The following is a description of a gene set: species: Homo sapiens Human Gene Set: GSE29618_BCELL_VS_MDC_DAY7_FLU_VACCINE_DN Genes down-regulated in comparison of B cells from influenza vaccinee at day 7 post-vaccination versus myeloid dendritic cells (mDC) at day 7 post-vaccination. Systems vaccinology has emerged as an interdisciplinary field that combines systems wide measurements and network and predictive modeling applied to vaccinology. Here we used the systems vaccinology approach to study the molecular mechanisms underlying th from publication Nakaya HI, Wrammert J, Lee EK, Racioppi L, Marie-Kunze S, Haining WN, Means AR, Kasturi SP, Khan N, Li GM, McCausland M, Kanchan V, Kokko KE, Li S, Elbein R, Mehta AK, Aderem A, Subbarao K, Ahmed R, Pulendran B (PMID 21743478), and this is the list of marker genes: HEXB, ROGDI (rogdi atypical leucine zipper), AHNAK, LGALS2, CYFIP1, RIN3, NREP, APMAP, MYCL (MYCL proto-oncogene, bHLH transcription factor), COTL1, PTPRE, NDFIP1, ALDOA, IL13RA1, PEA15, CASP1, CLIC2, ADAM8, ACTB, RTN4, TUBA1C, RAB7A, RAB31, CKLF, RGCC, FZD1, CLEC7A, CSF2RA, CD1B, PTMS (NCBI Gene Id 5763), SAMHD1, TPI1, LDLRAD4, GRN, LGALS9, ALDH2, CD1D, CLEC4A, LMO2, RAB32, SHTN1, OTULINL, C1orf54, DPYSL2, AHR, TGFBI, SEPTIN2, VCL, TIPARP, CLEC10A, CPVL, CST7, PPT1, ATP1B1, PON2, ACTN1, DOCK5, RCOR1, CD86, MACROH2A1, APAF1, SH2B3, KCTD12, CIDEB, FCER1A, CAT, PPIF, KLF10, PSAP, DUSP3, SPATS2L, PAK1, NAGA, FLT3, PLCB2, PSTPIP2, GSTP1, TOB1, CACNA2D3, ITGAX, ID2, LDHA, GNAQ, IGFBP7 (NCBI Gene Id 3490), PTTG1IP, TMEM43, CSTA, IL1RN, SEMA4A, LEPROT, CD63, ARRB1, MCL1, RNF130, BHLHE40 (basic helix-loop-helix family member e40), KLF4, NIBAN1, FCGRT, CREB5, SH3BP4, SLC25A5, ETHE1, DST, COL9A2 (NCBI Gene Id 1905), INSR, AP1S2, MAPKAPK3, MYL6, IMPA2, ANXA1, IL6R, CSGALNACT2, FBP1, RUFY3, PARK7, CLTB, TIMP1, ETS2, VIM, FCER1G, CD1C, GNA15, IL1R2, TUBA1B, AK2, RHOC, AOAH, GSN, RCAN1, LGALS1, RGS10, SORT1, RNH1, P2RY13, IL18, EFHD2, ATF3, CFP, LIMS1, RUNX2, CD33 (NCBI Gene Id 945), CEBPD, SIRPA, PGM1, GPX1, PLBD1, FKBP1A, SCNM1, SSR1, CSF1R, TNFSF13, NDRG2, CPQ, CD302, CD1E, ACAA1, TYROBP, OGFRL1, GNG5, SCD, GABARAP, GRPEL1, NACC2, DAPK1, APOBR, NDRG1, ICAM1, ATP8B4, STX3, RPS6KA4, MCTP1, LMNA, SLC30A1, CTBP2, EIF4A1, MGST2, ENO1, IGSF6, AIF1, CREG1, GRAMD4, TBXAS1, CHP1, ATP6AP1, LST1, TNFAIP2, ATG3, S100A4, CD4, ACTG1, PRKCI, APIP, S100A10, CST3, AP2S1, PADI2, PKM, ST3GAL6, RTN1, MYD88